Given this list of marker genes DNAJA3, LLPH, GOT1-DT, PSME3, ATF5, TTC32, CTDP1, PRKCI, POC1B-AS1, ACRBP, PIK3C3, CYB5A, CLPB, AGK, C1orf216, FNBP1P1, TYK2, TM2D3, CCDC12, HTD2, DDX23, TRA2A, ZNF786 (NCBI Gene Id 136051), VPS33A, FAHD1, OGFOD2, UQCRC2, GTF3C2-AS2, CTDP1-DT, CZIB-DT, HEXA-AS1, SP7, AJUBA-DT (NCBI Gene Id 107984660), POC1B, MSL3-DT, ZNFX1, CCNI, ZNF444, PRKAB2, C2orf49, DAD1, CCDC163, HARS1, ANXA2R, RARA, BCAT1, MIR4795, PIGB, GTF2H4, MYO9B, GSPT1, CRY1, GART (NCBI Gene Id 2618), TNPO3, MPHOSPH10, HARBI1, CXXC1, ZWILCH, NUP62, TMBIM4, UBB, PPIB, CAND1, SSBP1, GSTCD, HAUS8, U2AF2, GALM, ACHE, BECN1, PWP1, TOLLIP, SMG7-AS1, PPWD1, DLAT, SON, NEK10, GABPB1-AS1, CEP44, PFKM, CDCA2, LINC02983, WNK1, SNRPA1-DT, CCDC124, TP53BP1, SHC1, NPM3, UBE2I, POLR1G, PPP1R13L, SUZ12P1, C3orf38, CTDSPL2, SCAF11, SLTM, SRRM2-AS1, INKA2, FBXL19, EPHA4, RAD51AP1, SNORD12C, ENSG00000241525, INTS12, GINS4, TUBD1, POC1B-GALNT4, CYB561D2, ELP3, CDKN2A, HMGB1, GMNN, ESRP1, IFT70A, EBLN3P, LENG8-AS1, SERF2, FAM89A, ATM, GGH, MRPS17, IP6K2 (inositol hexakisphosphate kinase 2), ZNF436, MT1X, TIMM22 (NCBI Gene Id 95988), SPOP, LRR1, CZIB, LAMTOR4, HYCC2, SRRM2, ERBB3, SLBP, ATXN2L, YARS2, GTF3C2, CDCA3, CRADD, AGBL3, KANK1, WEE2-AS1 (NCBI Gene Id 285962), STARD5, USP48, MSL3, PCLAF, PSMD14-DT (NCBI Gene Id 102723949), MKLN1-AS, TMEM230, FBXL19-AS1, ST6GAL2, SCAMP1, DKK1 (NCBI Gene Id 22943), SPCS3, PUS7L, CNOT2, COQ5, BLOC1S2, THUMPD1, BCCIP, RFX2, CFAP61, NFKB2, POLR3G, ABCB9, MYLK-AS1, PRPF31, ETS2-AS1, NPAT, NT5C3A, CBLL1-AS1, GARS1, PSMD14, LAPTM4A (lysosomal protein transmembrane 4 alpha), ZNF561-AS1, PCIF1, TXNRD1, C10orf88, SUCLG1, STX5, METTL25, LINC01023, ABHD10, MTBP, NEDD8-MDP1, CFL1P1, RPA3, EIF3D, UROS, MYO1B, YAF2, POC5, RN7SL181P, MEF2A, ATP6V1D (NCBI Gene Id 51382), ENSG00000246308 (NCBI Gene Id 101928053), LRRC23, WDR77, ACTR2, HEXA, COX10-DT, CCDC59, ABCA5, COQ10B, STPG2, ADAM11, GCHFR, KBTBD2, CKS1B, MIR3913-1, VPS13B-DT, TMEM87A, CHMP2B, TBC1D8B, IL4I1, EMG1, PCBP1, CATSPERG, TMEM182, TRMT11 (NCBI Gene Id 60487), STAT6, FCMR (NCBI Gene Id 9214), POLR2F (NCBI Gene Id 5435), POMT2, RPL41, MAP3K5, NEMF, THOC1-DT, UMAD1, EIF4G2, LIPT1, PIGBOS1, KDM3A, NDUFA11, WARS2, UCHL5, CRNKL1, KCTD9, NEDD8, STX3, CALM2, SMG7, SEPTIN7-DT, FBXO16, H4C4, XRCC5, ZNF557, CLPTM1, PRMT3, DHX29, TMC3-AS1, SEPSECS, ATAD1, PCBP1-AS1 (NCBI Gene Id 652470), RTTN, SEPTIN7, RBM12B-DT, ZDHHC5, ANO6, GABPB1, KLRG1, COQ4, ZNF335, MDP1, CASKIN2, CCDC97, RSRC2, MPI, RDM1, ZNF770, RO60, BOD1, PRR11, BBS2, MRPS33, NDUFAF4P1, USP30, TPR, SZRD1, TSGA10, PROX1-AS1, GMPR2, SKIC8, KLHL22, MCEE (methylmalonyl-CoA epimerase), SDR39U1, C2orf49-DT, USP37, MYG1 (NCBI Gene Id 60314), SKAP2, CBLL1, ATP5MC3, HDAC2-AS2, SP8, TFPT, STAT5A, CACTIN, NUBP1, HACD2, ZBED5-AS1, ARFIP1, DCTN5, ABCF2, CENPT, THAP11, MLH1, VMAC, SLC25A12 (solute carrier family 25 member 12), SETD7, EIF3E, NAPA-AS1, CNOT1, ODR4, MMACHC, THOC1 (NCBI Gene Id 9984), NAB2, TSEN54, SFSWAP, GTF3A, TXNDC17, TMEM70, RAPGEF3, TSPAN5-DT, LIAT1, MDH1, SETD5, GALNT4, VARS2, ZCWPW1 (zinc finger CW-type and PWWP domain containing 1), ENSG00000282936, ZNF24, RPP14, PTPRZ1, PKIG, RPL28, RAB14, MATCAP2, KIF3B (kinesin family member 3B), HEXIM1, AFF1, WARS2-AS1 (WARS2 antisense RNA 1), KNTC1, SEPSECS-AS1, CDC42SE1 (NCBI Gene Id 56882), UBN2, PDK1, SENP1, VTI1A, TUT1, TSPAN5, COPS2, RAB33B, GORAB, ZDHHC6, ZBED5, NDC1, NEMP1, EPM2AIP1, ATF4 (activating transcription factor 4), SMIM15-AS1, DOHH, SCARB1, GOT1, SNRPA1, HSDL2-AS1, TRIP4, WDR6, CFDP1, LAPTM4A-DT, FBXO8, ATG4C, NPEPL1, SGF29, GANC, MIR4258, CGGBP1, RNF187, ZBTB40, GABPB2, VPS13B, GTF3C6, MSH2, TBK1, THUMPD3-AS1, DGKH, LYRM2, AP1G1 (adaptor related protein complex 1 subunit gamma 1), TBRG4, MRPL13, BAZ1B, ADGRL1, MRS2, MAP3K7, INKA1, SPPL2A, TRUB2, RAB27A, TMEM248, RBM12B, DOCK8-AS2 (DOCK8 antisense RNA 2), ETV1, HAGH, CENPK, ITGB3BP, LENG8, YEATS4, GDAP1, FIS1, ADAMTSL5 (NCBI Gene Id 339366), STX5-DT, WDPCP, SPG21, ZFAS1, SNX10-AS1, GLS2, PHB2, WDR93, MEPCE, NPRL2, FAM53C, PRKG1-AS1, FERRY3, TPI1P2, M6PR, FBXO33, RPL4, KLC4, RPS6KB1, COPG1, NDUFB3, CORO7, SLC35A3, GPATCH1, SNX2, WTAP, VPS41, RBL1, TTC32-DT, ARMC8, PROX1, ZNF561, PCGF1, CTDSPL2-DT, ZNF687, HDAC2 (NCBI Gene Id 3066), FEM1A, MBLAC2 (NCBI Gene Id 153364), LRP6, COX10, ATP5PB, RB1CC1, PEF1, ATG13, FAM222A-AS1, COPS4, PALB2, KIAA1958, KIAA0753, LARP4, MRPL2, DDA1, ADGRE2, PEF1-AS1, SDF2, DOC2A, DDX55, CCT2, ZNF614, LARS2, MKLN1, AJUBA, ELOC, SRCAP, AGPAT1, VPS52, CROCCP2 (CROCC pseudogene 2), KPTN, ZSCAN29, VEZT, BRPF1, IRAK4, GSTZ1, LRIG2-DT, RAPGEF6, GORAB-AS1, MRPL33, SIRT4, RPS18, DIXDC1, POP7 (NCBI Gene Id 82671), AGTRAP, ZNF436-AS1, SAE1, TRMO, RAD51, ITFG2-AS1, ACTR8, CNOT9, C22orf23, DAZAP2, NR6A1, ABTB2, GOLGA3, NDUFB8, PAIP2, USPL1, EIF2S1, RFC2, FXYD5, NEK9, here is a description of the gene set: from publication Yevshin I, Sharipov R, Kolmykov S, Kondrakhin Y, Kolpakov F (PMID 30445619) Human Gene Set: RFX7_TARGET_GENES species: Homo sapiens Genes containing one or more binding sites for (RFX7) in their promoter regions (TSS -1000,+100 bp) as identified by GTRD version 20.06 ChIP-seq harmonization.